Given this list of marker genes DIP2B, SPAG9 (NCBI Gene Id 9043), N4BP2L1, TTYH2, PEX11A, NOX1, PTK2B, PDE7A, RPH3AL, USP12, DRD1, ATXN1, SEMA6A, CADM2, UBL3, BET1, CPSF6, RNF10, OSBPL8, MORF4L2, RAD51B, ANKIB1, ADD1, SEPTIN8, SEH1L, PANK3, TNRC6B, EN2, RPA1, AZIN1, CAMSAP2, SPATS1, SOX6, GPR6, FAM168A, ESCO1, ZNF432, IRF2BPL, SLC39A10, VAMP4, FBXO34, TFAP2B, NAMPT, ANKRD63, KCTD20, PHC1, ZNF747, SIAH1, MARCHF7, ATP6V1A, OGT, RC3H1, DCC, ANKFY1, ETNK1, MBD5, TBCEL, ADCY7, CLASP2, PSMD5, MAP3K9, AKIRIN2, LDB2, ADGRL2, BTNL3, STMN2, ATP6V1B2, GPM6A (NCBI Gene Id 2823), PRR11, WSB2, CPEB4, NFIB, RORA, SNRPB2, SMARCA1 (NCBI Gene Id 6594), GLRX, DMRTA2, SIN3A, GPR12, NR2C2, TNPO1, TNS3, FNBP1L, ATP8A2 (NCBI Gene Id 51761), EGR2, ARCN1, YWHAG, ZNF430, PPP6R3, PPP2R2A, PAPPA, SF3A1, ST13, BMAL1, SARAF, SYN2, KDM3B, EIF4G3, NCAM1, GFPT1, EXOC5, KCNIP4, HACD2, TMEM35A, CDK2, THOC2, GDNF (NCBI Gene Id 2668), here is a description of the gene set: Human Gene Set: MIR6757_3P from publication Chen Y, Wang X (PMID 31504780) species: Homo sapiens Genes predicted to be targets of miRBase v22 microRNA hsa-miR-6757-3p in miRDB v6.0 with MirTarget v4 prediction scores > 80 (high confidence targets).